Given this list of marker genes SDSL, SDS, RIDA, here is a description of the gene set: In many mammals, threonine can be catabolized either via mitochondrial L-threonine 3-dehydrogenase (TDH) to yield acetyl-CoA and glycine or via cytosolic L-serine dehydratase/L-threonine deaminase (SDS and the related SDSL (SDS-like) protein) to yield 2-oxobutanoate. Data from rat liver suggests that usage of the two pathways varies with physiological state (Bird & Nunn 1983). Studies of healthy human subjects suggest that almost all threonine catabolism follows the 2-oxobutanoate pathway consistent with the finding that the human genomic TDH gene appears to encode a product that would be mis-spliced and catalytically inactive. Human threonine degradation is therefore annotated here as the conversion of threonine to 2-oxobutanoate and the related conversion of 2-iminobutanoate to 2-oxobutanoate. Reactome Pathway: Threonine catabolism part of: Metabolism of amino acids and derivatives species: Homo sapiens